The following is a description of a gene set: Perineal hypospadias Human Gene Set: HP_PERINEAL_HYPOSPADIAS Hypospadias with location of the urethral meatus in the perineal region. species: Homo sapiens, and this is the list of marker genes: GATA4, SOX9 (NCBI Gene Id 6662), AR, SRD5A2, DNAJC19, HSD3B2 (hydroxy-delta-5-steroid dehydrogenase, 3 beta- and steroid delta-isomerase 2)